Given this list of marker genes FGF12, MIR328, ATP1A1, GPD1L, KCNE3, SCN3A, SCN2A, SCN3B, JUP, DLG1, KCNE5, CAV1, BIN1, SCN8A, KCNJ3 (NCBI Gene Id 3760), CACNA1C, CACNA2D1 (NCBI Gene Id 781), KCNA5, SNTA1, ANK2, CACNA1G, SCN5A (NCBI Gene Id 652341), KCNJ5, KCNJ8, KCNH2, GJA5, MIR1-1, KCNN2, KCNE1, SCN7A, SCN1B, DSC2, NUP155, FLNA, SCN9A, CASQ2, NOS1AP, CACNA1D, SCN2B, KCNJ2, GJC1, NOS1, SCN11A, SCN1A, DSG2, SCN4A, KCNE4, TRPM4, PKP2, KCND3, RNF207, CACNB2, CTNNA3, KCNE2, GJA1 (gap junction protein alpha 1), DSP, RYR2, SCN4B, MIR133A1, NEDD4L, CAV3, SCN10A, KCNQ1, here is a description of the gene set: species: Homo sapiens An action potential that occurs in a cardiac muscle cell and is involved in its contraction. Human Gene Set: GOBP_CARDIAC_MUSCLE_CELL_ACTION_POTENTIAL_INVOLVED_IN_CONTRACTION